The following is a description of a gene set: Human Gene Set: GOBP_REGULATION_OF_CELLULAR_RESPONSE_TO_HYPOXIA studied in species Homo sapiens Any process that modulates the frequency, rate or extent of cellular response to hypoxia., and this is the list of marker genes: AJUBA, CHCHD2, EPHA4, COMMD1, MIR210, MIR21, ENO1, HYOU1, NFE2L2, ROCK2, STAT3, PINK1, TMBIM6, PIK3CB, EGLN1, DDAH1, MAP2K1, KCNK2, DNMT3A, MIR145, NOL3, USP19, VHL, DRD2